The following is a description of a gene set: Human Gene Set: WP_5Q35_COPY_NUMBER_VARIATION 5q35 copy number variation studied in species Homo sapiens, and this is the list of marker genes: PTPN2, RNF44, BRCA1, ARFGAP2, GRIN1, FBXW7, FAM193B, H2AX, IGF1R, DRD2, SNCB, NELFB, GNAI3, CDHR5, HIC2, GRK6, SOS1, RGS14, COX5A, CYP7A1, BARD1, COX7C, MT-CO1, MYC, UIMC1, CAPN3, PFN3, SIMC1, FGF19, CLTB, BABAM2, BRCC3, PRELID1, RAB24, COX7B, EIF4E1B, LMAN2, CDHR2 (cadherin related family member 2), NOP16, GRB2, COX7A1, SRC, DBN1, FAF2, NSD1, MT-CO2, COX4I1, ABHD5, COX6B1, TMED9, COX6C, H3-3A, GRIN2B, KDM6B, SLC34A1, MYO7B, ABRAXAS1, DOK3, ANKS4B, TPM2, MXD3, PRR7, EED, DDX41, PTH, PNPLA2, TMED10, USH1C, MIR4281, GNAI2, COX8A, UNC5A, HIGD2A, SNCA, BABAM1, COX5B, FRS2, PLCG1, MAGED1, MAPK8, MT-CO3, MAPK9, MAX (NCBI Gene Id 4149), GPRIN1, ZNF346, JUN, PDLIM7, MIR1271, TSPAN17, CXCR4, ADAM10, F12, PTPRN2, INPP5D, GAB1, PIK3R1, KIAA1191, ARL10, TRIAP1, HK3, HIP1R, FGF1, B4GALT7, TMED2 (transmembrane p24 trafficking protein 2), MAPK10, NTN1, HIP1, ABL1, GNAI1, FGFR4, COX6A1